The following is a description of a gene set: Human Gene Set: GOBP_COMPLEMENT_ACTIVATION_LECTIN_PATHWAY species: Homo sapiens Any process involved in the activation of any of the steps of the lectin pathway of the complement cascade which allows for the direct killing of microbes and the regulation of other immune processes., and this is the list of marker genes: KRT1, FCN2, FCN3, COLEC10, MASP1, SERPING1, MBL2, COLEC11, MASP2, A2M, FCN1